Given this list of marker genes Tfap2b, Ints6l, Git2, Bphl, Kif1c, Slc26a7, Rimoc1, Rps7, Polr2a, Lce1a2, Saa3, Esrp1, Lad1, Kmt5a, Ms4a6d, Rpl37, Mapre2, Rsad2, Eprs1, Gclc, Pgd, Plod2, Set, Bicd2, Tuba4a, Rps24, Pip5k1a, Nectin2, Timmdc1, Lasp1, B2m, Ccdc43, Krt35, Pigo, Pmepa1, Ubc, Max, Hadh, Prr13, Tyrobp, Ncoa5, Glipr1l2, Uap1, Itpr3, Efna3, Impact, Mybl2, Spesp1 (sperm equatorial segment protein 1), Pfn2, Wrap73, Galnt11, Krtap19-5, Vdr, Krt32, Krt31, Smarcd2, Tia1, Krtap14, Nudt7, Aldh1a3, Rnf14, Hras, Krtap9-22, Mt4, Ucp1, Kpna6, Cpt1a, Tnfrsf19, Plxna2, Tro, Prnp, Krtap21-1, Pitx2, Snx17, Gm57857, Gna13, Ndufs4, Ppp4r3b, Adamts4, Chek2, Klhl13, Igfbp4, Cpsf4, Fermt3, Lpcat1, Hoxa3, Hnrnpll, Atf3, Vapb, Prokr1, Trp53inp2 (NCBI Gene Id 68728), Eps8l1, Mrpl52, Cebpb, Aqr, 2510002D24Rik, Usp19, Fkbp5, Gas1, Calr, Srsf3, Trh, Brd3, Morc3, Rbbp8, Polg, Srek1, Snrnp27, Tmem222, Lmbr1, Cacfd1, Ppib, Ldhb, Mbd3l2, Il18r1, Lsr, Tenm2, Triap1, Fa2h, Mtrex, Krtap4-13, Clcn3, Cdkn1c, Flna, Trib1, Rtraf, Ltbp2, Pdcd7, Krtap15-1, Lama5, Acan, Etfrf1, S100a8, Ece1, Rxylt1, St14, Krt33b, Scara3, Krt6b, Krt86, Klra4, Agpat5, Lce1f, Slc39a14, Ecrg4, Havcr2, Ahr, Egr2, Kdm5b, Krt34, H2bc4, S100a3, Rpl37a, Lce1i, Gstp2, Slc6a4, Pip4k2a, Ctnnal1, Aff2 (NCBI Gene Id 18428), Ncdn, Esd, Slc22a2, Csrp3 (cysteine and glycine-rich protein 3), Nherf2, Krt27, Rps6, Ctnnbip1, Rps17, Il33, Krtap16-3, Diaph3, Ginm1, Cd36, Psors1c2, Basp1, Mcl1, Pdgfc, Krtap19-3, Sfrp2, Klk1b27, Ctf1, Krtap19-1, Fzd6, Cd248, Retreg3, Serpinb9c, Txndc12, Hmgcs1, Tnni1, Ptprz1, Rps8, Dhx40, Npm3 (nucleoplasmin 3), Tpsb2, Adh1, Eln, Pip, Lce1h, Tgfbi, Actc1, Krtap6-5, Fcgr2b, Csnk1d, Supt6, Dus1l, Bag4, Cct6a, Tor2a, Me1, 9530068E07Rik, Nfib, Mbp, Rdh10, Zmym4, Grhl1, Shisa2, Msx2, Edaradd, AI661453, Eftud2, Immp2l, Smoc2, Krtap6-7, Bicc1, Smad4, Cops9, Cdk2ap1, Spon2, Os9 (amplified in osteosarcoma), A030005L19Rik, Rps25, Sptbn2, Tm6sf1, Ccdc137, Ccn3, Prkce, Gsta2, Celf1, Pfkfb3, Nsmaf, Krt71, Marcksl1, Hsd17b11, Myh3, Alox5ap, Tmem106c, Lipa, Zbed3, Litaf, Rpl26, Slc1a5, Rab4a, Ndst2, Tchh, Tfpi2, Tle3, Ndrg1, Nfe2l3, Wdr75, Srgn, Crym, Zfp330, Pip5k1c, Rpl27, Chst1, Tmcc2, Ift46, Lig3, Arhgef25, Hdc, Zdhhc14, Parp3, Aldh3a1, Capzb, Rbbp4, Ackr1, Atp5if1, Virma, Gsdma, Clec4e, Patz1, Cxcl12, Fnta, Tmed9, Agtr2, Dkk2, Sirpa, Klk10, Prss12, Galr1, Zic3, Ube2f, Rpl34, Krt33a, Zfp37, Cttn, Marcks (NCBI Gene Id 17118), Scmh1, Myo10, H2bc22 (H2B clustered histone 22), Npepl1 (aminopeptidase-like 1), Sntb2, Vmn1r46, Trbc1, Fbp1, Pank1, Itga4, Fubp1, Glo1, Tnnt1, Krt72, Atp6v0c, Dusp22, Lypd8l, Cyp2g1 (NCBI Gene Id 13108), Col18a1, Defb7, Krtap5-25, Krtap19-2, Marchf2, Prdx1, Zcchc9, Pigu (NCBI Gene Id 71347), Acyp1 (acylphosphatase 1), Nr2f1, Atp11a, Edc4, Enox2, Col11a1, Sp110, Gtf2b, Krtap8-1, Ppcdc, Krtap4-16, Arrdc4, Cox6a1, Grb10, Dlk1, Atf7ip2, Ltbp1, Ptgds, Ube3a, Hacd4, Atp5pd, Zfp574, 1700091H14Rik, Krtap12-1, Ptprf, Plgrkt, Foxo1, Lbp, Clpb, Rhou, Aldh1a7, Npy4r, Krtap3-1, Cibar1, Pkd1, Krt23, Pam16, Pax6, Celf4, Thra, Clip4, Slurp1, Pou1f1, Adgrg1, Cxcl14, Dvl1, Hspa8, H1f2, Npy, Lama2, Myh14, Hook2, Ms4a6b, Cdh5, Zfp410, Rilpl2 (Rab interacting lysosomal protein-like 2), Pkig, Gm42047, Ighg2b, Gprc5d, Ifi205 (interferon activated gene 205), Tnnt2, Krtap6-1, Igdcc4, Mgll, Car6, Tspan3, Bambi, Calcoco2, Fxyd4, Fam162a, Idi1 (NCBI Gene Id 319554), Mtx1, Zfp280d (NCBI Gene Id 260391), Slc44a1, Csf1r, Pom121, Rims2, Ppih, Sdhaf4, Dct, Dop1b, Cdkn1a, Krtap13-1, Crtc3, Psmc4, Rps18, Uty, Rpl14, Tgfb2 (NCBI Gene Id 98738), Rhbg, Nfia, Ifi203, Slc14a1 (NCBI Gene Id 72142), Slc7a5 (NCBI Gene Id 270102), Siva1, Fhdc1, Capn6, Rpl21, Magohb, Cma1, Numa1, Dap, Cnot4, Naa12, Lxn, Homer2, Sox11, Tc2n, Dynlt1b, Bcr, Clns1a, Fzd7, Asb6, Aars1, Krtap20-1, Trim2, Ssbp2, Mfap5, Igfbp2, Maml1, Son, Mfap3, Map4, Pcbp2, Cd163 (NCBI Gene Id 93671), Slc39a6, Dstyk, Tnmd, Sppl2b, Epas1, Iffo2, Lyar, Dnpep (NCBI Gene Id 98181), Zfp521, Tjp2, Rps21, Itgav, Mta1, Edn3, Krtap6-2 (NCBI Gene Id 16701), Pinlyp, Pilra, Slc27a4, Psmf1, H2-D1, Sox2, Padi3, Golga4, Atf1, Mndal, Kera, Krtap28-13, Pttg1, Gzmb, Krtap19-9b, Irx4, Pea15a, Dpysl3, Krtap9-1, Sox9, Tmem191, Faap20, Tex261, Msr1, Krtap9-3, Defb6, Krt25, Pkp2, Tbk1, Plac1, Rpgrip1, Tnnc1, Wfdc21, Agfg2, Tmem109, Mrtfa, Apoe, Dctn4, Meis2, Sprr2a1, Tmed10, Rnf149, Fastkd2, Slc45a3, Ly6a, Slc35b1, Clec10a, Nadk, Huwe1, Pdgfa, Mup1, Vmn1r49, Fbn2, Ly6g6d, Ccn1, Ripk4, Krtap6-3 (keratin associated protein 6-3), Enpp3 (ectonucleotide pyrophosphatase/phosphodiesterase 3), Ap2a1, Egln3, Elovl6, S100b, Notch1 (NCBI Gene Id 68125), Zscan26, Atp2a2 (ATPase, Ca++ transporting, cardiac muscle, slow twitch 2), Scyl1, Bbox1, Lancl1, Bbip1, Plxnb3, Krt82, Tnfaip6, Pttg1ip, Neo1, Pigq, S100a14, Ubb, Poldip3, Ints9, Spint1, Upp1, Cpa3, Ushbp1, Xpo5, Chac1, Selenof, Eif3e, Tomm70a, Canx, Smo, C1ra, Rrn3 (NCBI Gene Id 98048), Six2, Krtap5-2, Krt81, Dtx3, Krtap1-5, Fbxw8, Krtap19-4, Cxxc5, Krtap4-2, Mllt1, Rhbdl3, Man2c1, Sort1, Tnrc6a, Gnmt, Fos, Qpct (NCBI Gene Id 70536), Ilf3, Mrpl33, Rcc2, Polr2l, Krt83, Ddx3y, Gjb2, Arl8b, Sfxn3, Col9a3, Acad8, Unc5b, Celsr2, Slc4a10, Serpinb1a, Ctla2a, Cyp11a1, Bad, Has3, Clu, Tardbp, Ndel1, Serpinb3c, Acvr2b, Rnaset2b, Ap2b1, Myl4, Sephs2, A030005K14Rik, here is a description of the gene set: Squamous cell carcinomas (SCC) represent the most aggressive type of nonmelanoma skin cancer. Although little is known about the causal alterations of SCCs, in organ-transplanted patients the E7 and E6 oncogenes of human papillomavirus, targeting the p53- and pRb-dependent pathways, have been widely involved. Here, we report the functional consequences of the simultaneous elimination of Trp53 and retinoblastoma (Rb) genes in epidermis using Cre-loxP system. Loss of p53, but not pRb, produces spontaneous tumor development, indicating that p53 is the predominant tumor suppressor acting in mouse epidermis. Although the simultaneous inactivation of pRb and p53 does not aggravate the phenotype observed in Rb-deficient epidermis in terms of proliferation and/or differentiation, spontaneous SCC development is severely accelerated in doubly deficient mice. The tumors are aggressive and undifferentiated and display a hair follicle origin. Detailed analysis indicates that the acceleration is mediated by premature activation of the epidermal growth factor receptor/Akt pathway, resulting in increased proliferation in normal and dysplastic hair follicles and augmented tumor angiogenesis. The molecular characteristics of this model provide valuable tools to understand epidermal tumor formation and may ultimately contribute to the development of therapies for the treatment of aggressive squamous cancer. Genes down-regulated in mice with skin specific knockout of RB1 by Cre-lox. species: Mus musculus Mouse Gene Set: MARTINEZ_RB1_TARGETS_DN from publication Martínez-Cruz AB, Santos M, Lara MF, Segrelles C, Ruiz S, Moral M, Lorz C, García-Escudero R, Paramio JM (PMID 18245467)